Given this list of marker genes Kcnq2 (NCBI Gene Id 16536), Scn11a, Sod1, Cntnap2, Kcnq3, here is a description of the gene set: The initiating cycle of an action potential. In vertebrate neurons this typically occurs at an axon hillock. Not all initiated axon potentials propagate. Mouse Gene Set: GOBP_ACTION_POTENTIAL_INITIATION species: Mus musculus